Given this list of marker genes ZNF587, KMT5B, EIF1AX, IRF2BP2, G3BP1, YY1, AR, IBTK, MSI2, KMT2E, BASP1, GRINA, ENTR1, SOD1, PCBP2, GRB2, GNL3L, CBX4, JPT1, NUFIP2, PABPC1, NOL8, TUBA1B, HSPD1, NUCKS1, AK4, RALA, HSP90AA1, METTL2B, DDX17, CELF1, GIT1, ZNF605, H2AZ2, DENND11, LARP1, UGT2B15, here is a description of the gene set: studied in species Homo sapiens BACKGROUND: Prostate cancer is characterized by heterogeneity in the clinical course that often does not correlate with morphologic features of the tumor. Metastasis reflects the most adverse outcome of prostate cancer, and to date there are no reliable morphologic features or serum biomarkers that can reliably predict which patients are at higher risk of developing metastatic disease. Understanding the differences in the biology of metastatic and organ confined primary tumors is essential for developing new prognostic markers and therapeutic targets. METHODS: Using Affymetrix oligonucleotide arrays, we analyzed gene expression profiles of 24 androgen-ablation resistant metastatic samples obtained from 4 patients and a previously published dataset of 64 primary prostate tumor samples. Differential gene expression was analyzed after removing potentially uninformative stromal genes, addressing the differences in cellular content between primary and metastatic tumors. RESULTS: The metastatic samples are highly heterogenous in expression; however, differential expression analysis shows that genes are upregulated and genes are downregulated at least 2 fold in every patient with metastasis. The expression profile of metastatic samples reveals changes in expression of a unique set of genes representing both the androgen ablation related pathways and other metastasis related gene networks such as cell adhesion, bone remodelling and cell cycle. The differentially expressed genes include metabolic enzymes, transcription factors such as Forkhead Box M1 (FoxM1) and cell adhesion molecules such as Osteopontin (SPP1). CONCLUSION: We hypothesize that these genes have a role in the biology of metastatic disease and that they represent potential therapeutic targets for prostate cancer. from publication Chandran UR, Ma C, Dhir R, Bisceglia M, Lyons-Weiler M, Liang W, Michalopoulos G, Becich M, Monzon FA (PMID 17430594) Top genes up-regulated in metastatic vs primary prostate cancer tumors. Human Gene Set: CHANDRAN_METASTASIS_TOP50_UP